The following is a description of a gene set: Binding to a polymer of the small ubiquitin-like protein SUMO. Mouse Gene Set: GOMF_SUMO_POLYMER_BINDING species: Mus musculus, and this is the list of marker genes: Casp8ap2, Sobp, Rnf4, Rnf111, Simc1